The following is a description of a gene set: Ca2+ entry, Ligand-gated Ca2+ channel. Pathway ID: N01642. Pathway type: Reference. Pathway class: nt06528 Calcium signaling. Pathway Definition from KEGG: Ca2+(extracellular) -- LGCC -> Ca2+(cyto) Human Gene Set: KEGG_MEDICUS_REFERENCE_CA2_ENTRY_LIGAND_GATED_CA2_CHANNEL studied in species Homo sapiens, and this is the list of marker genes: P2RX7, GRIN2C, P2RX3, GRIN2A, P2RX5, P2RX6 (purinergic receptor P2X 6), P2RX4, P2RX2, CHRNA7, GRIN2D, P2RX1, GRIN1